Given this list of marker genes F7, P2RY12, MCFD2, ITGB3, ITGA2B, F13B, VWF, GP9 (glycoprotein IX platelet), F8, LMAN1, TPM4, SERPINE1, F10, F5, GP1BA, F13A1, GP1BB, here is a description of the gene set: Prolonged bleeding after surgery Bleeding that persists longer than the normal time following a surgical procedure. Human Gene Set: HP_PROLONGED_BLEEDING_AFTER_SURGERY species: Homo sapiens